The following is a description of a gene set: Genes up-regulated in comparsion of sfActCD4 versus WTActCD4 (see Fig. 1 in the paper for details). species: Homo sapiens Human Gene Set: GSE7460_FOXP3_MUT_VS_HET_ACT_TCONV_UP The transcription factor Foxp3 is usually considered the master regulator for the CD4+CD25+ from publication Hill JA, Feuerer M, Tash K, Haxhinasto S, Perez J, Melamed R, Mathis D, Benoist C (PMID 18024188), and this is the list of marker genes: FCGR2A, OCIAD2, RAB39B, RTL8C, DOK2, SRGN, IQCF5, ANK1, SIRT7, ENPP3, MEIOB, STX3, TM9SF1, SLC37A3, BSDC1, TRABD2B (TraB domain containing 2B), MAF, SLC9A1, KRTAP20-2 (NCBI Gene Id 337976), GLRX, CD200R1, TOM1L1, RSPH1, GABARAP, TBX6, PRLR, MAPK4, B4GALT7, MYD88, MYO10, RNASE6, GASK1B, ARPC3, DOCK5, ZNF394, SLC35A2, S100A6, ECE1, TRAPPC14, TCTA, KHDRBS2 (KH RNA binding domain containing, signal transduction associated 2), RMDN2, OTOP2, ATP13A5, GPR15, FSCN3, SV2C, GSTT1 (NCBI Gene Id 2952), LTB4R, VSTM5, MYO9B, FGA, SNCA, TGFB2, CASR, GPX8, IGFLR1, ASB2, N4BP1, COMMD4, SERPINA11, GPR171, NUDT7, KRT18, GZMA, KLRD1, TIPARP, BLOC1S3, FLYWCH1, SUSD3, SLC25A20, HOMEZ, TAFA3, HCG4, HIP1, RABEP2, ABHD6, MANSC1, TBCB, GC (GC vitamin D binding protein), NEUROD1, KCNJ10, FOXD2, SGPP2, ZNF471, CCIN, SPP1 (NCBI Gene Id 6696), EFCAB6, CRLF2, RUNX3, IGFBP6, WDR81, TRIM65, DNAJC1, IRAK4, ZNF572, MON1A, GRB2, LGALS3, TAS1R2, ADAMTSL3, DEF6, SYCE1, C12orf75, B3GNT6, DENND11, SCCPDH (NCBI Gene Id 51097), MYO1A, MFAP5, SEMA4F, FBXO17, MRPL33, PTPRN2, SUMF1, MED12L, PRSS37, OAZ3, IGHG1, SMUG1, ZDHHC11, ADAMTS3, CSF1 (NCBI Gene Id 1435), HEBP1, H2BC18, MYO5B, PIK3CG, NUCB1, DRAM1, B4GALNT4, IFITM2, GPR107, HHIPL1, FAM83E, GCG, HOXA1, GBX2, ARHGAP33, HSD3B2, KLK10, PRR14, SPMAP2L, LOXL2, PFKFB4, IL12A, GCNT1, SLC9A4, ABHD2, ERMN, SZT2, FRMD4B, CXCL1, ALG1, ESM1, MYH8, SYT13, ADAR, TNFSF13B, UNC80, TNC, NUMBL, HS3ST1, JAM3, TBC1D5, ANXA11, CLIP3, DENND1C, CALHM2, FLOT1, EHBP1L1, RUNX2, KLRC1, PPM1J, ORAI1, ELMOD1, UCP2, GIPC2 (GIPC PDZ domain containing family member 2), SLC25A35, KLRK1, SYT17, SEC14L2, TWF2, SDC4, PKHD1L1, GDAP1, ATP6AP1, PXN, IKZF4, AGBL3, ARPC4, MSC, ARTN, LRTM1, MYLK4, HPCA, EPB41L5, CEBPB, FKBP9, SMIM14, IFI44, TCP11